The following is a description of a gene set: A benign or malignant neoplasm that arises from or metastasizes to the brain. studied in species Homo sapiens Brain neoplasm Human Gene Set: HP_BRAIN_NEOPLASM, and this is the list of marker genes: ZFTA, AAGAB, POLD1, TMEM106B, VCP, PSEN1, FLI1, MAPT, APC, RB1, POLE, NF1, TREM2, COL14A1, GRN, CHMP2B